The following is a description of a gene set: Human Gene Set: WP_FOLATE_METABOLISM Folate metabolism species: Homo sapiens, and this is the list of marker genes: NFKB1, FOLR1, INS, MTHFD1, FGB, SHMT1, SOD3, GPX6, IZUMO1R, RFK, IL4, CSF1, PLAT, CTH, TNF, APOB, GART, CRP, FLAD1, FGG, GPX3, RELA, MTHFD2, SLC46A1 (NCBI Gene Id 113235), GPX1, MTHFS, TP53, IL2, SERPINA3, ALB, GPX4, IFNG, SAA2, SAA4, CBS, F7, PLG, CAT, SOD2, MTR, AHCY (NCBI Gene Id 191), APOA1 (NCBI Gene Id 335), FOLR2, MTRR, IL1B, IL6, DHFR, SAA1, SOD1, SLC19A1, MPO, HBA1, CCL2, ABCA1, MAT1A, FOLR3, MTHFR (methylenetetrahydrofolate reductase), SERPINE1, GPX2, INSR, FGA, SAA3P, HBB, NFKB2 (NCBI Gene Id 4791), ICAM1, SHMT2, SCARB1, F2, LDLR